The following is a description of a gene set: studied in species Homo sapiens from publication Chen Y, Wang X (PMID 31504780) Genes predicted to be targets of miRBase v22 microRNA hsa-miR-708-3p in miRDB v6.0 with MirTarget v4 prediction scores > 80 (high confidence targets). Human Gene Set: MIR708_3P, and this is the list of marker genes: MYEF2 (myelin expression factor 2), VIM, P2RY13, TBC1D30, GPRASP3, CXXC5, FADS1, METTL8, CLEC7A, PHF20L1 (PHD finger protein 20 like 1), UNC79, ABRAXAS2, RNF182, BBX, PSAT1, JARID2, OTUD3, DHX40, MSI2, ATG7, CDH6, C7orf57, TRAPPC6B, GABBR1, SLC25A46, VDAC2, RHAG, ZDHHC23, SCAMP1, NEFL, CDY1, AIG1, SYTL4, CLOCK, ABHD5, P2RY1, LNPK, CDY1B, PTGER3, TRAF3, CTTNBP2, TMF1, ZNF518A, TMBIM6, CAPZA2 (NCBI Gene Id 830), SPRED1, CDK13, PLCB4, SH3TC2, RGN, LDLRAD3, AKAP13, CIAO2A, ALCAM, PLPPR1, FGR, DDHD2, YWHAB, RPTN, ASAP1, TENT4B, AP3M1, ANKRD42, MAML3, EPB41L3, CFAP298, CDYL2, GTPBP1, XPO7, DAAM2, ZEB1, CHRDL1 (chordin like 1), TPGS2, ZNF687, RAD51AP1, BORA, LPP, DYNLT3, TRIM9, STRN3, FGF14, ETNK1, BAZ1B, AQR (aquarius intron-binding spliceosomal factor), ATF7, LARP4, LHX9, GLB1L3, AHCYL2, PSIP1, ZNF592, ABCA5, NEIL2, LRRC59, CATSPERB, TJP1, PPHLN1, SDHAF3, HECA, ARHGAP17, SETMAR, POLR1D, PPP1R15B, GPD2, ZFHX3, ADAMTS3, HSPA4L, CELF2, EMP1, CNST, TOP3A, USP42, PLEKHH3, ARHGAP5, C1GALT1